The following is a description of a gene set: Enables the transmembrane transfer of an inorganic ion by a channel that opens in response to a change in proton concentration (pH). Human Gene Set: GOMF_PH_GATED_MONOATOMIC_ION_CHANNEL_ACTIVITY species: Homo sapiens, and this is the list of marker genes: ASIC2, PKD2L1, ZACN, ASIC1, ASIC3, PKD1L3, PACC1, AQP6